Given this list of marker genes KAT2B, RBPJL, PTF1A, PDX1, NOTCH1 (NCBI Gene Id 54781), CTNNB1, FGF10, HES1, NKX6-1, RBPJ, PROX1, here is a description of the gene set: Human Gene Set: WP_PTF1A_RELATED_REGULATORY_PATHWAY PTF1A related regulatory pathway species: Homo sapiens